Given this list of marker genes GJA5, FGF13, CALM1, RYR2, SLC4A3, CAV3, HCN4, HCN1, JUP, BIN1 (bridging integrator 1), TRPM4, DLG1, CACNA1C, MIR208A (NCBI Gene Id 406990), CXADR (NCBI Gene Id 95792), DSC2, CTNNA3, ATP2A2, HCN3, RANGRF, PKP2, TMEM161B, CAMK2D, DSP, ANK2, CAV1, NOS1AP, CALM3, TBX18, AKAP9, DSG2, here is a description of the gene set: Human Gene Set: GOBP_REGULATION_OF_CARDIAC_MUSCLE_CELL_ACTION_POTENTIAL species: Homo sapiens Any process that modulates the frequency, rate or extent of action potential creation, propagation or termination in a cardiac muscle cell. This typically occurs via modulation of the activity or expression of voltage-gated ion channels.